The following is a description of a gene set: Mouse Gene Set: CUI_T_CELL_GD_GM_CSF_RESPONSE_UP Genes positively differentially expressed in cell type: γδ T cell upon treatment with cytokine: GM-CSF in mouse lymph nodes in vivo. from publication Cui A, Huang T, Li S, Ma A, Pérez JL, Sander C, Keskin DB, Wu CJ, Fraenkel E, Hacohen N (PMID 38057668) Cytokines mediate cell-cell communication in the immune system and represent important therapeutic targets. A myriad of studies have highlighted their central role in immune function, yet we lack a global view of the cellular responses of each immune cell type to each cytokine. To address this gap, the authors created the Immune Dictionary, a compendium of single-cell transcriptomic profiles of more than 17 immune cell types in response to each of 86 cytokines (>1,400 cytokine-cell type combinations) in mouse lymph nodes in vivo. A cytokine-centric view of the dictionary revealed that most cytokines induce highly cell-type-specific responses. For example, the inflammatory cytokine interleukin-1β induces distinct gene programmes in almost every cell type. A cell-type-centric view of the dictionary identified more than 66 cytokine-driven cellular polarization states across immune cell types, including previously uncharacterized states such as an interleukin-18-induced polyfunctional natural killer cell state. species: Mus musculus, and this is the list of marker genes: Cxcr6, Wdr83os, Rexo2, Pdia6, Pdia3 (protein disulfide isomerase associated 3), Calr, Capg, Maf, Crlf2, Spcs2, Pon2, Tmem176b, Sdf2l1, Pdia4, Hsp90b1, Ppib, Ppp1r14b, Mrpl42, Ly6e, Ckb, Lgals1, Ciao2a, Actn2, S100a11, Manf, Prdx1, Eif5a, Cyba, Cap1, Tmem203, Ramp1, Sec11c, Ddost, Pgk1, Ndufa12, Ltb4r1, Rtf2, Tmed2, Nme1, Cfl1, Uqcc4, Blk, Mrps12